Given this list of marker genes MTOR, NOP53, NCL, PIH1D1, MACROH2A1, SMARCB1, IPPK, MARS1, DEDD, SMARCA4, SIRT7, DDX11 (DEAD/H-box helicase 11), PWP1, NOL11, MACROH2A2, here is a description of the gene set: Any process that modulates the frequency, rate or extent of transcription of nuclear large rRNA mediated by RNA polymerase I. studied in species Homo sapiens Human Gene Set: GOBP_REGULATION_OF_TRANSCRIPTION_OF_NUCLEOLAR_LARGE_RRNA_BY_RNA_POLYMERASE_I